Given this list of marker genes SEMA6A, TRMT61A, ARL2BP, OSBP2, COPS7B (NCBI Gene Id 64708), ITCH, TTYH3, RPIA, ARRB1, ATP2B2, CLDN18, TMCC3, GIPC3, SRSF7, KLK4, CERS1, SH3PXD2A, AP5B1, NCOR1, FBXO41, GSK3A, LIFR, IQSEC2, CPEB3, KIAA0930, RAB5A, CNP, RAP1GAP2, BCAM, NATD1, TYSND1, NKAIN2, ENG, ZBTB4, SLC2A8, MYO1C, UBA1, RNF20, ZFR2, CPLX2, FAM219A, ARID3B, ABCF1 (ATP binding cassette subfamily F member 1), ST3GAL1, JMJD8, PPIE, ZNF672, CLCF1, EVC, EEFSEC, KIAA0513, NECTIN1, ZNF609, PLXDC2, PPP3R2, LZTS1, TAOK2, DNAJB5, SDC3, PEX14 (peroxisomal biogenesis factor 14), PHLDB1, TOX2, PAX7, GNAI2, TRAF7, LRP1, CNIH2, VAMP1, TM2D3, LARP1, GPRIN1, RAB6B (RAB6B, member RAS oncogene family), CLIP3, NKIRAS2, GRIK3, MPZL2, GFI1, SEMA7A, TTLL6, TAGLN, SLC45A2, BCL2L13, ACVR1B, PKP2, CDYL2, TTL, SMPD3, RELT, ADGRL1, SLC12A4, RPL28, FBXL16, ACE, TRPM3, CDR2L, ARHGAP1, TRAF1, SHB, PRLHR, SLC6A17, CRTC1, SYNDIG1L, ABCF2, SYNJ1, HOXA7, BTF3L4, MDGA1, STRBP, RAB35, JPH3, SYT7 (synaptotagmin 7), MBTD1 (mbt domain containing 1), REXO1, STUM, DENND2B, PACS1, SPOCK2, APC2, SH3PXD2B, NPTX1, ZNF395, PLXNA1, GLIS2, YY1AP1, CPSF7, ZFP41, IGFBP5, CUEDC1, NFIC, WARS1, PRCD, MTCL2, CLDND1, NAP1L3, EIF5, OLFML2A, CLDN19, ZNF346, GPBP1L1, MFAP1, SDK2, PPIL2, ERC1, NMD3, GNG13, APLN, GAB1, PTPRF, AOC3, NFIX, SEPSECS, KIF21B (kinesin family member 21B), KCNS1, CDC42SE1, PPM1H (protein phosphatase, Mg2+/Mn2+ dependent 1H), WDR48, PKIG, PKLR, TBL1XR1, NDRG4, PMM2, PDE4D (NCBI Gene Id 654081), ACVRL1, ZNF219, PML, STK40, PARVG, HSPB6, CLCNKB, KCNIP3, SZT2, MECP2, CTCF, MAP6D1 (NCBI Gene Id 79929), SON, here is a description of the gene set: species: Homo sapiens from publication Chen Y, Wang X (PMID 31504780) Human Gene Set: MIR762 Genes predicted to be targets of miRBase v22 microRNA hsa-miR-762 in miRDB v6.0 with MirTarget v4 prediction scores > 80 (high confidence targets).